Given this list of marker genes NPTX1, SIAE, HSDL2-AS1, ATRX, MCF2, RALGPS2, SMPD4, PDCD11, INCA1, EFCAB14, NOSIP, CNOT1, CSNK1E, ATP5MK, PZP, DPP9, CYP4Z1, KDM2A (lysine demethylase 2A), SLC66A1, FIS1, GCDH, FAM76A (NCBI Gene Id 199870), ARSA, RPA2, ZNF184, LINC01992, PTPRG, OACYLP, NDUFAF1, WDR83OS, LINC02109, RYR1, NPRL3, USP47, SRRM5, RC3H1, SECTM1, FRS2 (NCBI Gene Id 10818), PTGES2-AS1, TTLL2, CCL20, ANKH, ANO10, EIF3B, ZNF407, STK36, RN7SKP68, AHSA1, RDH12, CNTNAP4, NAPA-AS1, UBE2V1, PITPNA, KPTN, SNX15, PYCR2, HEXIM1, RPL7P54, DSP, TAFA3, MAN2C1, MEIS2, TMBIM1, ZNF410, KRT18P68, MIR4638, SEMA3F, AATF, HERC3, ZNF148, JRK (NCBI Gene Id 8629), C1orf174, SMC2, MIR4727, SPA17, SPTB, ZNF7, ELAPOR1, SDHAF3, ERRFI1-DT, KMT2D, MPP2, HOMER1, RPS3A, RCAN1, MIR22HG, BTF3-DT, GAPDH, ERRFI1 (ERBB receptor feedback inhibitor 1), EPB41L5, ZFHX3-AS1, MAPK10-AS1, LINC00612, RASA1, CALM1, ADAM15, KICS2, ATF7, FBXO38-DT, NUF2 (NCBI Gene Id 83540), SPRR3, FBXO31, RIC8A, SNORA14B, ENSG00000232995, IRGQ, TBC1D8, RPS11P1, MROH6, PTGES2, RAB12, ZNG1E, FAM89B, BRSK2, CELSR2, ZNF511, RPS29P24, ASH2L, OPTN, LINC01968, KCNK15-AS1, KIF1C, RN7SKP85, CWC25, FLVCR1, CYC1, CHRD, STXBP1, KRR1, GGA1, TFEC, ZNF576, ZNF687, TNFSF13, TRIM41, AP3M2, MAT2A, PDLIM1, HCP5, MIPOL1, RGS5, SSU72, USP16, CCDC136, DPYSL4, WDR83, RN7SL93P, RCC2, ELF1, FBXO38, RNF25, here is a description of the gene set: from publication Yevshin I, Sharipov R, Kolmykov S, Kondrakhin Y, Kolpakov F (PMID 30445619) Genes containing one or more binding sites for (COBLL1) in their promoter regions (TSS -1000,+100 bp) as identified by GTRD version 20.06 ChIP-seq harmonization. species: Homo sapiens Human Gene Set: COBLL1_TARGET_GENES